The following is a description of a gene set: Human Gene Set: HE_LIM_SUN_FETAL_LUNG_C5_LARGE_PRE_B_CELL Large pre-B studied in species Homo sapiens from publication He P, Lim K, Sun D, Pett JP, Jeng Q, Polanski K, Dong Z, Bolt L, Richardson L, Mamanova L, Dabrowska M, Wilbrey-Clark A, Madissoon E, Tuong ZK, Dann E, Suo C, Goh I, Yoshida M, Nikolić MZ, Janes SM, He X, Barker RA, Teichmann SA, Marioni JC, Meyer KB, Rawlins EL (PMID 36493756), and this is the list of marker genes: EXOSC10, NSD2, SFR1, SAMHD1, TMEM106C, GMPS, TESMIN, URM1, NAA50, PSPH, CNOT10, TASL (TLR adaptor interacting with endolysosomal SLC15A4), CEP131, C8orf33, AAAS, MPHOSPH9, EDC4, TK1, E2F1, ALDH7A1, FAM98B, TRIM28, TIMM44, PSRC1, TCEAL3, MFAP1, LMAN1, MAD2L1, ASL, ABCD3 (NCBI Gene Id 5825), RUNX1, LAGE3, ZNF738, PIDD1, LCORL, EIF2B3, DDX11, TPRKB, RANGRF, GTF3C5, USP1, ANLN, BTG3, H2AC21, TM7SF3, CPSF2, HASPIN, DHRS4L2, MIS12, TMEM14A, NUDT15, HADH, IGF2BP1, PTP4A3, HENMT1, KHSRP, RBMX2, RNF26, EIF2S1, NUDCD2, CFAP20, TFPT, CENPA, PPP1R35, HMGXB4, BRAT1, NUDCD1, ALG8, BOLA3, PTTG1, SMS, MRPS27, PITHD1, RCOR1, WBP4, RBM10, TCEA2, DIS3L, TOE1, NIPSNAP1, TTI2, CNP, PLGRKT, CC2D1A, NCAPH, ANAPC7, NABP2, LIN9, PAK1IP1 (NCBI Gene Id 55003), MRPL11, ACAT2, SLX1A, TRAPPC4 (trafficking protein particle complex subunit 4), PRADC1, SPRTN, SLC16A1, FADS2, AHCYL1, IFT27, TEX30, PCLAF, THAP7, MAP3K20, GEMIN2, PPIL3, GEN1, CDC5L, ELP6, CKAP2L, ISYNA1, GCHFR, METTL4, AGO2, POLA1, ACLY, BIRC5, PAICS, ASPM, ITGB3BP (NCBI Gene Id 23421), ATP1A1, MXD3, MTHFD1, PSMD14 (proteasome 26S subunit, non-ATPase 14), TSPO, KIFC1, CCDC14, CENPO (NCBI Gene Id 79172), H2AC15, CCDC34, BLMH, MCM7, DERA, SAE1, HAUS8, IMPDH1, RNF168, GALK1, CDC20 (cell division cycle 20, NCBI Gene Id 991), MYBL2, SKP2, PRKDC, SKIC8, KIF18A (kinesin family member 18A), DYNLL2, MRPL55, RPE, PAXBP1, OTULIN, PHF6, GINS4, MRTO4 (NCBI Gene Id 94394), NNT, ILVBL, CLN6, MGST2, NFYB, CENPX, HPF1, NIPSNAP3A, CDKN2AIP, CSRP2, FAF1, PPAT, SRP68, ZNG1B, UFD1, ICMT, ABHD12, FAM72B, CSTF2, GET1, NCAPD2, RECQL, SPDL1 (NCBI Gene Id 54908), MOV10 (NCBI Gene Id 57723), IRAK1, CDC7, SMIM19, RECQL4, PBK, VPS72 (NCBI Gene Id 6944), PPIE, ETFB (NCBI Gene Id 2109), ECT2, PDHA1, RBL1, RHNO1, EMC6, BRIX1, CHEK1, POLE2, SKA2, WDR54, MLH1, ATAD3A, AAGAB, PDCD7, CENPU, APMAP, H3C8, BCR, H2AC4 (NCBI Gene Id 8335), PCGF6, PDZD11, TYMS, FANCL, TPP2, KIAA1143, SARS2, SEC22B, SLBP, H2BC15, ALDH18A1 (NCBI Gene Id 9193), CKAP2 (NCBI Gene Id 55221), CALU, ZNF714, TAF6, WRAP53, OAT, XPO1, TBCD, EZH2, H3C15, DHFR, TACC3, ANKRD26, ASRGL1, NDUFA8, UQCC5, HPRT1, CRNDE, CENPK, ELP4, NFATC2IP, APEH, PPIL1, CENPJ, PSMD9, H2AC11, TBP, ALYREF, UBAP2, UTP18, TRAP1 (NCBI Gene Id 51721), CCDC86, NUF2, ATIC, CENPF, PMVK, C5orf34, HAUS4, LAS1L, APOO, BCL7C, CTSC, RUVBL1, BRD3, MAZ, TGS1, HDGF, FANCI, MRPS9, NUP85, CKS1B, RARS1, CNOT9, PRR11, ACAT1, EI24, TST, MKI67, ARL1, GINS2, FKBP3, NUP54, TOR2A (NCBI Gene Id 84633), HEBP2, BCKDK, ZCCHC17, RAD51AP1, SORD, HDHD2, HAUS1, LRRC58, RACGAP1, TRIP13 (thyroid hormone receptor interactor 13), SLX1B, GCDH, TRAPPC2L, H3C3, GPANK1, FAM111A, CDC27, RAD54L, MGST3 (microsomal glutathione S-transferase 3), CLIC4, IPO7, TTI1, DCPS, SRPK1, TMEM70, GNA15, MLLT11, MDM1, SPIN1, CENPL (centromere protein L), AP1S1, NAA20, ARMC1, GMPPB, ARMC6, HMGB3, OGFOD1, LETM1, PRPS1, CCDC81, SNHG10, MRPL9, PTPN11, SESTD1, UQCC3 (ubiquinol-cytochrome c reductase complex assembly factor 3), CEP152, KATNAL1, CEP43, WDR5, DLEU2, CDK4 (cyclin dependent kinase 4), YWHAG, HERC5, RCC2, KIF11, CRLS1, CDCA5, ARHGEF39, ADK, EIF2AK1 (NCBI Gene Id 27102), RFWD3, SDF2L1, CDK19, HEBP1, ID2, NANS, NXT1, COX11, SPAG16, SNAP29, HDHD5, MRPL58, AIFM1, E2F7, RUSC1, TACO1, NEDD1, DNAJC11, CDK5 (NCBI Gene Id 1020), HMGN5, SUV39H1, MRPL49, SEC22C, MNS1, CMC2, FBXO5, NUP58, TMEM214, TDP2, ANKRD36B, DIAPH3, BID, MRPL17, BCL2L12, PPA1, BCAT1, DLGAP5, FAM136A, CMAS (NCBI Gene Id 55907), CASP2 (NCBI Gene Id 835), SNRNP48, CEP295, ILKAP, DDX1, HAUS6, ZNF639, HAUS5, RAE1, RAD18, PDRG1, FAHD2A, FBRSL1, MIS18A, VPS25, SART3, DOHH, CEP76, KPNA2, ASF1B, MTFP1, SUMO3, CFAP36, RCC1L, PPP1R7, CETN3, SUZ12, PMPCA (peptidase, mitochondrial processing subunit alpha), CDKN2A, SLC25A11, UQCC4, SLC35A4, PARP2 (poly(ADP-ribose) polymerase 2), ISOC2, PHTF1, SGTA, CNOT11, RPP30, POLD2, SRGAP2B, CDK1, TMEM11, NAA10, NARS1, AARS1 (NCBI Gene Id 16), CEP85, MESD, GPN3, SFXN1, COPS8, SARNP, SCCPDH, MNAT1, ERAL1 (NCBI Gene Id 26284), PTPMT1, MICB, ZW10, SMIM24, UTP11, SUPT16H (SPT16 homolog, facilitates chromatin remodeling subunit), INTS13, RBM28, BRF1, CDT1, CCP110, TUBB3, CDC25C, TEDC1, PSMD12, MTX1, SEPHS1, FANCD2, RMND5B, TROAP, TMEM14C, DCTPP1, WBP11, GOT1 (glutamic-oxaloacetic transaminase 1), DGCR6L, TOX, IVD, PPP5C, DAPK3, MAGEF1, HDGFL3, E2F4, RIF1, NUP93, UQCC2, TRIAP1, CDKN3 (cyclin dependent kinase inhibitor 3), AFG3L2, ODF2, BAHCC1, GART, SPATS2, CYREN, UCK1, HMMR, NUBP2, RNASEH2A (ribonuclease H2 subunit A), PRMT5, RMDN1, BRD7, KIF23, CIAO3, TMPO-AS1, BDH1, HAGH, DTL (NCBI Gene Id 51514), ACOT13, PABPC4, POLR2F, IMMP1L, CCNG1, WDR83, GLRX5, NUP62, SAMD1, TCOF1, CD320, LRRC59, FADS1, FN3KRP, TPX2, NME4, MRPS24, SMYD3, MLST8, ADISSP, HTRA2, RBBP8, MSH2, SPC24, EIF2B1, H2BC7, PRPF4, CDKN2AIPNL, FOXRED1, CCDC88A, SCLT1, OXCT1, MCAT, SAAL1, NUCB2, ANAPC15, PRPF31, ASH2L, TARDBP, BCL7B, MASTL, CENPH, SMARCD1, ZNF367, MMS22L, UBE2M, DNM1L, TMEM203, LRRC45, CCNB1, AP3B1, MRPS28, DCUN1D5, STAG1, FAM216A, ETS2, H3C2, IARS1, IFRD2, KIF4A, HJURP, KNL1, CHML, POLD1, ISOC1, TRAF2, CCDC77, HAUS2, GDE1 (glycerophosphodiester phosphodiesterase 1), EPB41L2, SLC25A17, NNT-AS1, CEP55, ARL6IP6, ELP5, CLSPN, MTMR2, IPO5, IPO9, DVL2, UMPS, PDCD5, HCFC1, BAZ1B, AHI1, MND1, TEDC2, N4BP2, FABP5, UBL7-DT, ZNHIT3, ATAD2, HS2ST1, UBL4A, PRPS2, NEK2, XRCC1, TIPIN, SLC20A1, C12orf43, ADI1, ORC3, SRM, POLE, RCC1, GET4, SUGP2, ECI2, ERLIN1, CHD1L, INCENP, MRPL39, IMMT, CHTF18, CHAC2, ZWINT, AAMDC (NCBI Gene Id 79737), GLRX2, GSPT1, EFHD2, ALG5, FANCG, ATG10, RAB27A, SASS6, GNB1, FHL1, DDX52, CDC25A, CENPW, CKLF, MMAB, PAFAH1B3, SAR1A, CIP2A, GUSB, PAQR4, NAA15, APIP, MRPL21, G6PC3, NDC80, HARS1 (NCBI Gene Id 3035), BUB1B, MRPL35, YARS1, EIF2B2, COA6, MRPL27, EXOSC3, PLK4, EBP, AURKA, CCNA2, PHF19, THOP1, MAPKAPK3, BYSL, LMNB2, NCAPG, CENPQ, C21orf58, H2AC20, UBR7 (NCBI Gene Id 55148), POC1A, HELLS (helicase, lymphoid specific), MRPS11, RFC1, MRPS10, GTPBP6, CDC23, PPME1, CHTF8, BUB1, FOXM1, USP48, KPNA3, CPSF3, SRGAP2C, MFGE8, REV1, PLPBP, ABHD12B, RFC3, DSCC1, RAVER1, PSMA1, PNP, DDB2 (NCBI Gene Id 1643), MSH3, E2F8, NUP107, PLIN2, EBNA1BP2, VRK1, TAF5, SFXN4, TSEN15, H2AX, EXOSC2, GLRX3, CSRP1, H4C11, MAD2L2, USP14, THAP11, FUCA1, HACD3, PGD, C4orf46, NUP210, SNRNP25, SLC7A5, RFC5, LIN54, UBN1, YIF1B, PLK1, MRPL3, MTA1, GKAP1, DMAC2, HNRNPA1L3, TMEM97, TMEM209, H3C12, TOPBP1, LAP3, RPIA, ZNF93, IFITM1, PMS1, ZCCHC9 (zinc finger CCHC-type containing 9), FBXO22, NCBP1, GLE1, MRPS33 (NCBI Gene Id 65515), TLNRD1, FIGNL1, PSMG1, ZDHHC12, USP39, RPS6KB2, MRE11, THG1L, CTBP2, CEP41, DKC1, BAP1 (NCBI Gene Id 8314), POLD3, GTPBP4, CPSF4, XPNPEP1, NEK4, CTNNBL1, H2BC18, GAR1, ACAA2, DNTTIP1 (NCBI Gene Id 116092), MZT1, NUDT2, MLEC, TIMELESS, THUMPD3, DESI2, DDX49, BARD1, H2AC13, TSFM, CHAMP1, CTCF, ERI3, RPL26L1, SHMT1, POLR3K (NCBI Gene Id 51728), DDX41, MCM2, SLC29A1, MTRFR, UBE2S, CISD1, RAD9A, RNF8, NCAPD3, GGH, ANP32E, DLAT, PAXX, RMDN3, APOLD1 (NCBI Gene Id 81575), C9orf40, PARPBP (NCBI Gene Id 55010), NINJ1, PPA2, UBAP2L, NDUFS1, GMCL1, RTKN2, DONSON, NIF3L1, UBE2C, KMT5A, IGFBP7, PRXL2A, CAMK4, PSMD1, ATAD5, RAD1, TTC39C, PDS5B, CORO1C, SF3B3, C11orf98, SLC39A8, WWOX, NOLC1, EXO1 (exonuclease 1), KIF22, BRCA2, KNSTRN, EIF4EBP2, WDHD1, UBAC1, COMMD4, MORF4L2, RRM2, POLDIP2, TCHP, TUBA1C, TRAIP, CLPP, SYNE2 (NCBI Gene Id 26075), ACAD9, PGRMC1 (NCBI Gene Id 10857), PGP, DDX23, CMC1, RANGAP1 (Ran GTPase activating protein 1), MTA2, TMX1, PPT1, UNG, RCCD1, CENPN, ARID3A, PDCL, RFC2, CDK2AP1, CENPT, LIG1, COMTD1 (NCBI Gene Id 118881), H4C12, ASF1A, FAIM, IKZF2, CTNNAL1, COIL, RAD51C, NOP16, NTHL1, DEPDC1B, MRPS23, SCMH1, H2AC8, GPATCH4, GTSE1, FIRRM, TIMM21 (NCBI Gene Id 29090), AMOTL1, PRPF19, MRPL22, CCNB1IP1, SKA1, MTIF2, SPOUT1, HIRIP3, REXO5, EED, PKMYT1, PSMC2, CDCA3 (cell division cycle associated 3), SLC1A4, PRKAB1, CMSS1, FEN1, PSME3IP1, ANKRD36, MRPL13, NRM (nurim), ACOT7, AK3, USP5, POMZP3, EIF4EBP1, SPTSSA, ZNF726, NCAPH2, TMEM18, MPST, BRD8, HIBADH, STMN3, NEIL3, PLAA, MRPL2, SUV39H2, MRPS2, CBFB, GGCT, MFSD14B, GFER, WAPL, PAK1, AHCTF1, RDX, TRIM24, SPATA33, TTF1, PAFAH1B2, RAB3IP, SLF1, PSME3, FANCA, ENOPH1, MKKS, FAM120A, KIF20B, DAP, CTNNBIP1, FH, GSS, CTBP1, CASP3, MCM10, PHGDH, C6orf136, PTPA, KIF14, CENPM, SLC4A1AP, NUDT5, EXOSC9, DDTL, CDK2, AGGF1, RSRC1, CCDC25, FAM83D, RPA1 (NCBI Gene Id 6117), GFUS, MRPL47, YEATS4, POP7, RWDD4, SEPTIN11, KIF15, ING2, GINS1, RABL6, MCUR1, CSTF1, RTN3, HINT2, ERG28, NME1, PDHX, DNMT1, MAP2K2, MCM4, FBXL5, LIN52, TARS1, CDCA8, TXNRD1, MRPL46, NELFE, RIC8A, DYNLT2B, CSPP1, NDUFA9, FAM200B, SPC25, KBTBD4, ACTL6A, JPT1, AGPS, KATNB1, MRPL15, H3C10, SGO2, USB1, COA3, DNAJC21, DCAF15, MANF, EIF1AY, MRPS14, MRPL23, GINS3, RABIF, MED20, ABHD3, SLC25A40, TUBGCP3, ATPAF1, PCNA, EIF3B, VDAC3, SMC1A, TCF19, MTFR2, UQCRHL, DENND10, KIF20A, AK6, CAMTA1, ATP23, ORC1, PSMG3, FARSB, PANK2, CCNB2, DPYSL2, TRAF7, SMC2, MPC1, TAF1B, JMJD8, CDK5RAP2, DTYMK, KEAP1, TRMU (tRNA mitochondrial 2-thiouridylase), COA5, PGM2, SFMBT1, RMI2, FARSA, MAPKAPK5, FAM76B, LYAR, HAT1, CCNE2, BRCC3, ARHGAP11A, PIGX, H4C6, SAC3D1, DNAJC9, CBX5, TOMM70, PSMC3IP, LRR1, DLD, EFTUD2, H3C14, ELAC2, COPG2, BRI3BP, PRC1, GON7, FAM111B, PPP4R1, CHAF1B, CSE1L, LMNB1, MYCBP, ING1, COMMD2, CENPE, SNF8, REC8, AIMP2, TTK, CDCA2, EFCAB2, CWC27, C17orf75, H2AC17, NOC4L, TFDP1, XRCC4, ORC6, JADE1, DNA2, GMNN, HCFC1R1, FLOT1, COQ9, SUCLA2, RNPEP, PSAT1, CHRAC1, MCMBP, H2BC9, CHTOP, ACTN4, DPP3, DSN1, SLC1A5, ASXL1 (NCBI Gene Id 23393), PELP1, PPIH, RMI1, UHRF1 (NCBI Gene Id 96185), CHCHD1, KNOP1, C19orf48P, C12orf75, FAM72A, SMCO4 (single-pass membrane protein with coiled-coil domains 4), PDXK, RFC4, CFAP73, PPIF, DRG1, H2AC16, CYB5B, COQ4, PRPSAP1, ZCRB1, MT2A, ANKRD54, APOBEC3B, CENPP, DBF4, ZNF85 (NCBI Gene Id 7639), RPL39L, HDGFL2, IFT25 (NCBI Gene Id 51668), NENF, DNAJC1, NDUFAF8, UCHL3, IFT22, CDC45, MRM2, USP13, H2AC14, DAZAP1, HTATSF1, SDHAF3, H3C7, SVIP, EEF1AKMT1, TPGS2, TOP2A, SMPD4, GNL3, EXOSC8, AKIP1, TXNDC12, RRP1B, SEH1L, BLM, DYNC2I2, CEBPG, AKR7A2, CCDC167, LMF2, SLC2A4RG (SLC2A4 regulator), CDK9, BRCA1, NUP50, PGAP2, NAE1, ENOSF1, DEPDC1, ESCO2, NUSAP1, TIMM10, ZAP70, AGPAT2, EXOSC7, VMA21, PRDX4, NTPCR, NSMCE4A, THOC6, BOLA2B, GAMT, KDM1A, MTRF1L, DPM2, WDR76, CDK5RAP1 (NCBI Gene Id 51654), HYLS1, MRPS18A, JPT2 (NCBI Gene Id 90861), KIF2C (NCBI Gene Id 11004), CCNF, F8A3, CTPS1, WEE1, PCID2, NET1, ETF1, DDX55, UBE2T, CISD2, INSR, PSMB5, SHCBP1, GNAI1, CDC6, LDLRAP1, PIMREG, LYRM7, CSTF2T, AHCY, ANAPC2, HILPDA, SKA3, GOT2, UTP4, SLC25A39, SGO1, TRNAU1AP, TSR1, RBM15B, H1-5, ZNF771, POLQ, NOL10, SLC43A3, PSPC1 (paraspeckle component 1), E2F3, SNHG19, POLR2H, ECI1, MAP7D3, ZWILCH, NUDT7, MCM5, RRP1, POP5, CBR1, H2AC12, GNL1, CDKN2C (NCBI Gene Id 654235), NCAPG2, ANKRD36C, G2E3, TDP1, NUP37 (nucleoporin 37), PPP2R2D, MTX2, GBE1, MCM3, CHEK2, AIF1, RRM1, OGFOD2, CHAF1A, H2BC3, TSEN54, FUBP1, CASP8AP2, H4C4, MRPS12, DPM1, KLHL23, LEO1, HSPBP1, CEP70, RUFY1, REEP4, CLK2, ACYP1, GLYR1, TTC1, AURKB (aurora kinase B), TIMM29, NMRAL1, DIAPH1, MRPS16, GCSAM, TELO2, POLA2, UCK2, DLST, MTHFD2, GARS1, TBL3, HLTF, CYB5A, ARL6IP1, CCDC18, MRPL36, EIF4G1, ETHE1, CEP192, POLR2D, UBASH3B, HDLBP, CLEC11A, KNTC1, GSTO1, MRPS15, UBALD2, TTF2, TIMM23, TADA2A, MSH6, CDK16, CBX1, TIMM22, CPXM1, MCM6 (NCBI Gene Id 4175), NSMCE2, LIMS1, TIMM50, PDE12, TMEM126A, PPP2R5D (protein phosphatase 2 regulatory subunit B'delta), EMC8 (ER membrane protein complex subunit 8), CDCA4, EMC9, NUP155 (nucleoporin 155), MUTYH, PRIM2, CCHCR1, NDC1, TOMM40, STIL, IL7R, CKAP5, BUD13, TSN, C1orf35, TAF9B, RPA3, INIP, AP4M1, MAGOHB, RUVBL2, PRIM1, SMC4, CTDSPL2, MTLN (mitoregulin), GPSM2, CDCA7, MPHOSPH6, OIP5, LRRC40, ING5, MALSU1, E2F2, SMC5, APEX2, EPRS1, UCHL5, MRPL48, GET3, POP4, CEP78, SPAG5, RCN1, GTPBP3, CNTLN, ZNF76, PDLIM7, LRRC42, ITGB1BP1, PXMP2, MED4, INTS14, ASNSD1, KIF18B, TUBG1, CCZ1B, SMYD2, SIGMAR1, LRRCC1, PCNT, MELK, TMEM126B, NSL1, UBXN2A